The following is a description of a gene set: from publication Wright HJ, Matthews JB, Chapple IL, Ling-Mountford N, Cooper PR (PMID 18832737) Genes down-regulated in neutrophils isolated from: healthy versus patients with peridontitis. studied in species Homo sapiens Peripheral blood neutrophils from periodontitis patients exhibit a hyper-reactive and hyper-active phenotype (collectively termed hyper-responsivity) in terms of production of reactive oxygen species (ROS) however the molecular basis for this observation is yet to be determined. Our objectives were to identify genes differentially expressed in hyper-responsive peripheral blood neutrophils from chronic periodontitis patients relative to periodontally healthy controls and use this data to identify potential contributory pathways to the hyper-responsive neutrophil phenotype. Human Gene Set: GSE12484_HEALTHY_VS_PERIDONTITIS_NEUTROPHILS_DN, and this is the list of marker genes: SUGT1, ARHGAP35, TLR8, TMEM19, MAN2A1, CASP6, USP42, PSME3, WSB2, DDX5, GPR141, TNNI1, TRIO, NDRG3, SHLD2, ARHGAP10, GTF3C5, FAM118B (NCBI Gene Id 79607), LY9, SCAMP2, PPP2R1B, PEX2, SLITRK2, TMCO5A, EFR3A, FLG2, TRMT10B, FLRT2, PPP1R15B, MPP1, ELMOD1, CSRNP2, TOR3A, AQP9, GCSH, ZIC3, RAB3GAP2, MRPL3, SLC23A2, HYKK, PGD, NANOS2, PYGM, RINT1, LDOC1, CEP68, DRC3, DSE, PCBP1, NELFA, XKR8, FOXD3, DYNC2LI1, TUBGCP4, PSMA5, RHOBTB1, NSMCE2, MRPL20, CBFB, PLCXD2, ATP6V1B2, USPL1, PRPS1L1, SV2B (NCBI Gene Id 9899), CALHM6, PNLIPRP2, GRSF1, ZNF394, KRT26, ANKRD60, TGFBRAP1, TXNL4A, EIF2B5, SERTAD1, XPO5, NIFK, HEATR5B, PSMD6, FMO5, PSMD7, TEKTL1, RBSN, BFSP1, PREP, KLK10, B4GALNT3, RFPL3S (RFPL3 antisense), HOXC13, DEFB4A, CDK5R1, PRX, NME1, IPO4, CCDC115 (NCBI Gene Id 84317), RCL1, CMTR2, USP12, TMEM185B, VAV1, SLC15A5, RPAP3, ELAC2, RNF145, ADA, USP6NL, GJA5, DMC1, TTC27, HCFC1, NLRP6, PPP1R17, AQP11, DDR1, SLC4A2, PIK3R4, ALLC, TTC38 (NCBI Gene Id 55020), CLUAP1, GFM2, EIF4B, FBXW2, GCN1, TRPM3, HAPLN3, ISCU, FITM1, FBXW7, INPP5F, NME7, PRKAR2A, RASD1, RNPEP, THOC5, PTPRU, AIMP2, TAF8, MCUR1, KCNMA1, ATP6V0D1, NCDN, TSGA13 (testis specific 13), PPIA, FLNB, SLC30A9, DBH, AMPD1, POLE2, KHSRP, RPP14, DDOST, AGFG1, BEGAIN